Given this list of marker genes IGF1, GBA1, MDK, CDK5R2, HOXB2, AGTPBP1, LMX1A, WLS, NOG, ENSG00000274276, TP53, HNRNPD, SKOR2, MT-ND4 (mitochondrially encoded NADH:ubiquinone oxidoreductase core subunit 4), PTF1A, MAP2K1, SCN5A, SERPINE2, ITGB1, MECP2, CRKL, ZNF365, HES1, B4GALT2, SMAD1, GPR37L1, COMT, ATF2, LHX5, HNF1B, NAV2, ABAT, EZH2, CNTN1, ATF5, AARS1, FLNA, ATRN, PLXNA2, GART, CRK, CEND1, WNT7A, TTLL1, PSEN1, DLL1, AHI1, MT-CO1, SEMA4C, HOXB1 (NCBI Gene Id 3211), RPGRIP1L (NCBI Gene Id 23322), EPHB1, LPAR1, PDSS2, GPX4, FGF2, COQ8B, NEUROD2, NCOA1, CEP290, TBR1, FAIM2, TRNP1, MYO16, EN2, KIF14, TTC21B, NRXN1, LEF1, ATIC, CBS, GDF10, ABL1, NAGLU, PIANP, PTBP2, GLI1, PHOX2B, MYH10, SMO, NCOR2, ARCN1, EPHB2, PAK1, FOXP2, SPTBN2, SCRIB, GSX2, OTX1, SDF4, NLGN4X, LDB1, CDK5R1, SLC6A4, WNT1, SEZ6, CDK5, SLC25A46, PTPN11, HAP1, UQCRQ, HOXB3, BMP7, NEUROG3 (NCBI Gene Id 50674), DLC1, RORA, KCNC1, FZD4, CTNNA2, ATP7A, HERC1, EGF, EN1, HOXA2, POU4F1, NANOS1, CD3E, GBX2, KCNE1, ASCL1, LHX1, PSMG1, TUBA1A, CTNNB1, OGDH, GRID2, KAT2A, SEC24B, GNPAT, HSPA5, NCSTN, WHRN, BMP5, FCGR2B, PROX1, NFIB, NHLH2, KLHL1, BCL2, ALDH1A2, CLP1, GLI2, SHH, NEUROD1, ARL13B, MAFB, GABRB3 (gamma-aminobutyric acid type A receptor subunit beta3), PHOX2A, CBLN1, EGR2, ATP1B2, KNDC1, OPHN1, FOXC1, SSTR1, PRKG1, PTPRS, KDM2B, FKTN, DAB1, GATA2, TTBK2, RERE, here is a description of the gene set: Human Gene Set: GOBP_HINDBRAIN_DEVELOPMENT studied in species Homo sapiens The process whose specific outcome is the progression of the hindbrain over time, from its formation to the mature structure. The hindbrain is the posterior of the three primary divisions of the developing chordate brain, or the corresponding part of the adult brain (in vertebrates, includes the cerebellum, pons, and medulla oblongata and controls the autonomic functions and equilibrium).